The following is a description of a gene set: Human Gene Set: GSE23502_BM_VS_COLON_TUMOR_HDC_KO_MYELOID_DERIVED_SUPPRESSOR_CELL_UP Differentially expressed genes of CD11b+Gr-1+ immature myeloid cells (IMCs) in the bone marrow and colonic tumor setting of histidine decarboxylase (HDC)-KO mice were examined by microarray (Affymetrix Mouse 430.2 array). Myeloid differentiation-related candidate genes were sought to be isolated and functionally studied. from publication Yang XD, Ai W, Asfaha S, Bhagat G, Friedman RA, Jin G, Park H, Shykind B, Diacovo TG, Falus A, Wang TC (PMID 21170045) species: Homo sapiens Genes up-regulated in myeloid-derived suppressor cells with HDC knockout: bone marrow versus colon tumor., and this is the list of marker genes: TPRG1, THBS2, CER1, SARM1, PPP1R42, TCEAL8, CDHR4, SLC6A3, FOXF1, CDH10, MYH1, HESX1, VAT1, SH3GL3, NTM, GPR162, CHRNA3, NUFIP2, CYRIB, TCFL5, SIM1, TMEM72, PRPF39, RSPO3, PLPPR1, DEFB106B, IAPP, TANC2, C4orf54, PCDH8, TSPAN8, CNTN3, CD53, RAB4A, PCED1A, NUDT11, RIMBP3C, PTPN22, LRCH2, SPRR2A, VANGL2, IGKC, FRMD5, KCNC2, FSTL5, GCNT3, FBXL7, SLC38A4, CLRN3, TMEM52B, C1orf116, STARD9 (StAR related lipid transfer domain containing 9), SLC15A5, GPR62, SUCO, PRRG4, GLRB, PRELP, KRT4, CLMN, CENPP, SPOCK1, PLA2G4D, HNF1B, MTTP, KRT13, DMC1, SCN1A, SCGB3A1, RAPGEF6, MNX1, EXOC3L2, ZFPM2, SFMBT2, RICTOR (RPTOR independent companion of MTOR complex 2), CA8, MOXD1, CWF19L2 (CWF19 like cell cycle control factor 2), SEC14L5, SYP, SEPTIN4, ARPP21, SERPINB5, SPEN-AS1, HTR5A, EDA, HSF2, MYOD1, STEAP2, BHLHE22, CSMD1, LDB3, VEGFC, HAPLN1 (NCBI Gene Id 1404), COL8A1, BAALC, REG4, PRKCG, NLGN1, UROC1, C11orf52, RHO, SLC18A1, SLITRK4, PRSS54, ADAM28, CRP, GJD2, KCND2, CEP112, SLC24A2, LRRN3, ZNF43, HEBP1, DHX32, PAQR5 (NCBI Gene Id 54852), PCDH15, SLC29A4, EIF2S3 (NCBI Gene Id 8422), SLC2A2, PLA2G6, CHRNB3, KCNU1, C11orf87, GALNT3, NEK11, SOX1, PDE7B, HIF1A, HORMAD2, NEO1, GPAA1, ACTR3, CCR5, LAMP2, GPSM2, REC114, PSMF1, JCAD, FBXO43, TRHDE, TSPYL5, TAS2R4, FGF14, FAP, SLITRK1, SPTA1, DRAM2, FAT3, HOXA2, DRGX, KL, HMGN3, RBM24, CALHM4, ANG, MKRN3, BECN1, PYGO1, UBR1, AVPR1A, CIDEA, ABCC10, ABCA6 (ATP binding cassette subfamily A member 6), ZNF841, DDAH1, SLIT2, HOGA1, TLE4, MYOCD, UNC79, VWC2, LINGO3, NUP155, TUBG2, DCDC2 (NCBI Gene Id 606719), CFAP251, IRS1, TAMALIN, TSSK4, CPEB1, TERB2, DDO, ACTB, NAALADL2, GRIA2, TMEM30B, KRT79, GPR15, LRRC19, PPBP, CD28, MORF4L1, OR10J5, GLIPR1L1, DUOXA2, DBX1 (developing brain homeobox 1), SEZ6L2, CRHR1